The following is a description of a gene set: from publication Chen Y, Wang X (PMID 31504780) Human Gene Set: MIR494_5P studied in species Homo sapiens Genes predicted to be targets of miRBase v22 microRNA hsa-miR-494-5p in miRDB v6.0 with MirTarget v4 prediction scores > 80 (high confidence targets)., and this is the list of marker genes: TAF5, P3R3URF-PIK3R3, ZNF131, BTAF1, RHOBTB1, MEOX2, SAV1, IL1A, ITGA6, CACNA2D1, NLK, TOGARAM1, PTPN4, SETD5, PTBP2, FMN2, RNF24, JAK1, RANBP6, ALDOB, STK38, GGA2, MXD1, CABYR, SETD7, BOD1L2, ARHGAP29, GORASP2, TMEM115, PCTP, PIK3R3, PRKCA, HSPD1, CDKN2B, IGLL5, ALG2, SERF2 (NCBI Gene Id 88287), ZMYM3, SYT9, DMRT2, KRT33B